The following is a description of a gene set: Genes down-regulated during differentiation from large pre-BII to small pre-BII lymphocyte. from publication Hoffmann R, Seidl T, Neeb M, Rolink A, Melchers F (PMID 11779835) species: Mus musculus Gene expression profiles of five consecutive stages of mouse B cell development were generated with high-density oligonucleotide arrays from as few as 2 x 10(4) ex vivo isolated and flow-cytometrically purified cells. Between 2.8% and 6.8% of all genes change on differentiation from one cellular stage to the next by at least twofold. The entire pathway involves differential expression of 10.7% of all genes. Previously known expression patterns of genes (like surrogate light chain, RAG-1/2, MHC class II, mel-14 antigen) are confirmed. The gene expression patterns of the proliferating pre-BI and large pre-BII cells on the one hand, and the resting immature and mature B cells on the other hand, are most similar to each other. Small pre-BII cells display a pattern that is transitional between these two groups. Most of the genes expressed in early precursors are involved in general processes, like protein folding or cell cycle regulation, whereas more mature precursors express genes involved in more specific molecular programs (cell surface receptors, secreted factors, and adhesion molecules, among others). Between 19 and genes share a given expression pattern. Combining knowledge about gene function and expression pattern allows identification of novel candidate genes potentially involved in self-maintenance of pre-BI cells, allelic exclusion and pre-B cell receptor signaling in large pre BII cells, cell-cycle arrest of small pre-BII cells, propensity toward apoptosis or anergization in immature B cells, propensity toward cell division and activation in mature B cells, and stage-specific interactions with stromal cells in the bone marrow. Mouse Gene Set: HOFFMANN_LARGE_TO_SMALL_PRE_BII_LYMPHOCYTE_DN, and this is the list of marker genes: Aatk, Zg16, Hspb8, Anks3, Efnb3, Birc3, Wdsub1, Jun, Tbxa2r, Cd2, Klk1b16, Rabep1, Reln, Ighe, Galt, Spink1, Fhl1, Selenop, Srebf2, Abca1, Dbndd2, Rab4b, Lsp1, Spin1, Slc25a53, Nfkbiz, Kmt2b, Samhd1, Idua, Wt1, Rbp4, Hsd11b2, Fbp2, Ldaf1, Gja4, Evl, Hck, Col4a3, Actn2 (NCBI Gene Id 73715), Klk1b8, Got1 (NCBI Gene Id 14718), Ier3, Cyp2b13, Igsf10, Endou, Bcl3, Psen2, Rag1, Prm1, Pkib, Mdn1, Srf, Igkv17-127, Cd151, Pomc, Lipc, Il4ra, Capg, Pim2, Gpr137b, Cd55 (NCBI Gene Id 13136), Trdc, Prrg2, Capn1, Uba7, Serpina1f, Sbf2, Baz2a, Ank3